The following is a description of a gene set: Genes up-regulated in low grade (LMP and G1) serous ovarian carcinomas vs the higher grade invasive tumors (G2 and G3). Profiles of gene transcription have begun to delineate the molecular basis of ovarian cancer, including distinctions between carcinomas of differing histology, tumor progression and patient outcome. However, the similarities and differences among the most commonly diagnosed noninvasive borderline (low malignant potential, LMP) lesions and invasive serous carcinomas of varying grade (G1, G2 and G3) have not yet been explored. Here, we used oligonucleotide arrays to profile the expression of genes in a series of 57 predominantly stage III serous ovarian adenocarcinomas from 52 patients, eight with borderline tumors and 44 with adenocarcinomas of varying grade. Unsupervised and supervised analyses showed that LMP lesions were distinct from high-grade serous adenocarcinomas, as might be expected; however, well-differentiated (G1) invasive adenocarcinomas showed a strikingly similar profile to LMP tumors as compared to cancers with moderate (G2) or poor (G3) cellular differentiation, which were also highly similar. Comparative genomic hybridization of an independent cohort of five LMP and 63 invasive carcinomas of varying grade demonstrated LMP and G1 were again similar, exhibiting significantly less chromosomal aberration than G2/G3 carcinomas. A majority of LMP and G1 tumors were characterized by high levels of p21/WAF1, with concomitant expression of cell growth suppressors, gadd34 and BTG-2. In contrast, G2/G3 cancers were characterized by the expression of genes associated with the cell cycle and by STAT-1-, STAT-3/JAK-1/2-induced gene expression. The distinction between the LMP-G1 and G2-G3 groups of tumors was highly correlated to patient outcome (chi(2) for equivalence of death rates=7.681189; P=0.0056, log-rank test). Our results are consistent with the recent demonstration of a poor differentiation molecular 'meta-signature' in human cancer, and underscore a number of cell-cycle- and STAT-associated targets that may prove useful as points of therapeutic intervention for those patients with aggressive disease. from publication Meinhold-Heerlein I, Bauerschlag D, Hilpert F, Dimitrov P, Sapinoso LM, Orlowska-Volk M, Bauknecht T, Park TW, Jonat W, Jacobsen A, Sehouli J, Luttges J, Krajewski M, Krajewski S, Reed JC, Arnold N, Hampton GM (PMID 15558012) species: Homo sapiens Human Gene Set: MEINHOLD_OVARIAN_CANCER_LOW_GRADE_UP, and this is the list of marker genes: CTNNAL1, CAST, KIF13B, CDKN1A, TMX4, TSPAN3, ST6GALNAC2, EIF1, CLDN10, BMERB1, PARP4, BTBD2